The following is a description of a gene set: species: Homo sapiens from publication Nakaya HI, Wrammert J, Lee EK, Racioppi L, Marie-Kunze S, Haining WN, Means AR, Kasturi SP, Khan N, Li GM, McCausland M, Kanchan V, Kokko KE, Li S, Elbein R, Mehta AK, Aderem A, Subbarao K, Ahmed R, Pulendran B (PMID 21743478) Systems vaccinology has emerged as an interdisciplinary field that combines systems wide measurements and network and predictive modeling applied to vaccinology. Here we used the systems vaccinology approach to study the molecular mechanisms underlying the innate responses to the trivalent inactivated influenza (TIV) and live attenuated influenza (LAIV) vaccination in humans, and to identify early gene signatures that predict the magnitude of the antibody responses to influenza vaccination. Human Gene Set: GSE29615_CTRL_VS_LAIV_FLU_VACCINE_PBMC_UP Genes up-regulated in comparison of peripheral blood mononuclear cells (PBMC) from TIV influenza vaccinee pre-vaccination versus those post-vaccination., and this is the list of marker genes: CACNB1, PHLDA1, VAPA, SOD3, ROPN1B, DOK4, CPNE4, FBXL13, NDRG4, CCNG2, KCNJ15 (NCBI Gene Id 3772), SYF2, SLC45A4, CISH, CYSTM1, MKS1, HBB, ETF1, ERC2-IT1, GPR83, GABRE, ICAM3, C4BPA, MGAM, KCNJ2, IRF2BPL, UGT2B28, KCNJ8, ADGRG3, TESMIN, MKNK2, CA4, THBD, PLCH2, KBTBD8, TMEM167B, SIVA1, ETNK2, ZNF527, SECTM1, CSN1S1 (casein alpha s1), ACTL7A, SUSD4, GRM2, HEY1 (hes related family bHLH transcription factor with YRPW motif 1), IL1RAP, KCNJ5, MMP8, ENSG00000261327, TNFAIP6, RBM15B, RPGRIP1L, MCM9 (NCBI Gene Id 54844), SLC25A51, ZNF598, MMADHC, SERTAD1, CRISP3, SPAG11B, PLP1, DPM1, XAB2, BAIAP2L2, SAMD8, LMTK2, MMP9, CMTM2, LMCD1 (NCBI Gene Id 29995), ZC3H10 (NCBI Gene Id 84872), NT5DC2, NTNG1, TNFRSF17, DEFA4, FSTL5, DNAJC12, PRC1, ATL2, MOB4, CCDC157, ERI2, IFI27 (NCBI Gene Id 3429), PRSS33, MLF2, NCF4, NKX2-5, DCP1A, IL6, POU4F3, SLC25A28, MALL, BRIX1, C2orf49, MAPKAPK3, KCNV1, PCDHB1, RNASE3, AFAP1L2, PI3, CYP4F2, VDAC1, MMP25, DTL, RNF212B, ZFP91, MBOAT7, MORN5, CHI3L1, ANKRD52, RAMP2 (NCBI Gene Id 10266), LRRC8A, RNF19B, IGKV3-20, CCN3, LAMP3, C1QL1, GUCY2D, PCIF1, ALPL, TLK2, TMEM88B, HAS1, PEX12, ACTC1, RNF114, ANXA3, PCDHGA10, COLEC12, PHF13, PPRC1, ZFP36L1, COL11A2, SERPING1, IGHV7-81, IL5RA, RBP1, PLPPR2, TLX1, SPATA2, KCNK16, CYP4F3, USP30, EPHA8, GGT2P, TRAPPC13, ABTB1, CELF4, RGR, ADGRE3, CRYAB, GNG10, DPYSL3, SIPA1L2, TERT, ULK1, SLCO1C1, MAGEC3, LIMK2, TBC1D10B, ADRA2A, ATP1B1, DDX24, PROSER1, PEX13, TIGAR, CCL20, ENSG00000250685, PIEZO2, RSPO4, CXCL1, MUC13, TNFRSF13C, CEACAM6, PPP4R1, RASGEF1B, MBIP, PPM1D, CCR3, C15orf39, VNN3P, LYSMD3, ACOT12, FAM8A1, ZDHHC18, TFG, CAMKK1, LINC01012, TNFRSF10C, OR2K2, SESN2 (NCBI Gene Id 83667), TOP2A, RGS18, IP6K2